Given this list of marker genes SOD1, IL1B, SYCE3, CASP2, MAEL, KITLG, IL1A, UBE2B, UNC5C, DDB1, BAX, SYCP2, KIT, TEX11, YBX3, BCL2L1, TOPAZ1, PRKDC, here is a description of the gene set: species: Homo sapiens Programmed cell death of an errant germ line cell that is outside the normal migratory path or ectopic to the gonad. This is an important mechanism of regulating germ cell survival within the embryo. Human Gene Set: GOBP_ECTOPIC_GERM_CELL_PROGRAMMED_CELL_DEATH